The following is a description of a gene set: species: Homo sapiens Any process that modulates the frequency, rate or extent of mitochondrial DNA metabolic process. Human Gene Set: GOBP_REGULATION_OF_MITOCHONDRIAL_DNA_METABOLIC_PROCESS, and this is the list of marker genes: ENDOG, MPV17, LIG3, SSBP1, METTL4, STOX1